Given this list of marker genes Slc29a1, Slc28a2, Slc28a2b, Slc25a26, Slc29a2, here is a description of the gene set: species: Mus musculus Enables the transfer of a purine nucleoside, a purine base covalently bonded to a ribose or deoxyribose sugar, from one side of a membrane to the other. Mouse Gene Set: GOMF_PURINE_NUCLEOSIDE_TRANSMEMBRANE_TRANSPORTER_ACTIVITY